Given this list of marker genes Wnt3a, Dkk1 (dickkopf WNT signaling pathway inhibitor 1), Fzd7, Bmp4, Bmp2, Ccnd2, Mef2c, Hdac3, Arrb2, Nrg1, Tgfb1 (transforming growth factor, beta 1), Smad4, Myocd, Frs2, Gsk3b (glycogen synthase kinase 3 beta), Kat2a, Sox6, Dll1, Efnb2, here is a description of the gene set: studied in species Mus musculus Any process that modulates the frequency, rate or extent of cardiac muscle cell differentiation. Mouse Gene Set: GOBP_REGULATION_OF_CARDIAC_MUSCLE_CELL_DIFFERENTIATION